The following is a description of a gene set: Human Gene Set: GOBP_REGULATION_OF_SECONDARY_HEART_FIELD_CARDIOBLAST_PROLIFERATION Any process that modulates the frequency, rate or extent of cardioblast proliferation in the second heart field. A cardioblast is a cardiac precursor cell. It is a cell that has been committed to a cardiac fate, but will undergo more cell division rather than terminally differentiating. The secondary heart field is the region of the heart that will form the majority of the mesodermal component of the right ventricle, the arterial pole (outflow tract) and the venous pole (inflow tract). studied in species Homo sapiens, and this is the list of marker genes: HES1 (hes family bHLH transcription factor 1), NOTCH1, ISL1, SIX1, TBX5, CTNNB1, HAND2 (heart and neural crest derivatives expressed 2), MKS1, EYA1